Given this list of marker genes MICU1, SLC25A13 (solute carrier family 25 member 13), NADK2, SLC7A7, AASS, here is a description of the gene set: Abnormal circulating lysine concentration studied in species Homo sapiens Human Gene Set: HP_ABNORMAL_CIRCULATING_LYSINE_CONCENTRATION Any deviation from the normal concentration of lysine in the blood circulation.